The following is a description of a gene set: Human Gene Set: GOBP_REGULATION_OF_LEUKOCYTE_APOPTOTIC_PROCESS Any process that modulates the frequency, rate or extent of leukocyte apoptotic process. studied in species Homo sapiens, and this is the list of marker genes: BTK, TP53, ADAM17, LILRB1, PIP, MIF, HCAR2, SELENOS, ANXA1, ARG2, LYN, BBC3, PRKD2, LGALS3, RAPGEF2, KIFAP3, MIR17HG (miR-17-92a-1 cluster host gene), CCL5, NR4A3, WNT5A, SIRT1, GPAM, BCL2, SLC46A2, AURKB, JAK3, ORMDL3, BCL2L1, CD27, MERTK, MYC, BIRC7, FCAR, PTCRA, ZC3H8, PRELID1, PIK3CD, FADD, TGFB2, FOXP1, RAG1, CCL19, CD3G, MIR34A, NOD2, BCL6, HIF1A, PERP, CXCL12, NF1, IL10, GAS6, IRS2, MIRLET7B, CD74, IDO1, GIMAP8, ADA (adenosine deaminase), LGALS9, NOC2L, ADAM8, IL2, CD274, ITPKB, CCR7, HCLS1, GHSR, PIK3CB, AXL, ST3GAL1 (NCBI Gene Id 6482), FCER1G, SLC7A11, SLC39A10, TSC22D3, HSH2D, BCL2L11, IRF7, MEF2C, CCL21, FNIP1, PDCD1, KITLG, LGALS16, PRKCQ, IL7R, BCL11B, CCR5, STAT5A, P2RX7, BAX, RIPK3, BMP4, EFNA1, BCL3, CDKN2A, RORC, DOCK8, BCL10